Given this list of marker genes MYMX, CHN1, ROBO3, SALL4, MYMK, MAFB, here is a description of the gene set: An impaired ability of the eye to move in the outward direction (towards the side of the head). Human Gene Set: HP_IMPAIRED_OCULAR_ABDUCTION Impaired ocular abduction species: Homo sapiens